Given this list of marker genes Fam107a, Fscn1, Lima1, Vil1, Gas2, Actb, Actn4, Ppp1r12c, Cttnbp2nl, Septin5 (NCBI Gene Id 29860), Coro1b, Pdlim1, Klhl2, Coro2b, Evl, Fhod1, Nebl, Myh11, Sh2b2, Pdlim2, Cnn2, Pgm5, Pxn, Bloc1s6 (NCBI Gene Id 56387), Dctn4, Tek, Ppp1r12a, Septin11, Myl12b (NCBI Gene Id 98057), Ptk2, Marcks, Myh7, Pls3, Pdlim5, Xirp2, Vcl, Amot, Lpp, Myh14, Pls1, Sipa1l3, Myh9, Fblim1, Lcp1, Ablim3, Ldb3, Gas2l2 (growth arrest-specific 2 like 2), Cryab, Rflnb, Gas2l1, Prkcz, Enah, Micall2, Mlph, Afap1l1, Myl12a, Rflna, Shroom4, Dst, Limch1, Luzp1, Pdlim4, Ilk, Zyx, Prickle4, Afap1, Actn1, Tpm4, Flnb, Tlnrd1, Tmsb15l, Myl9, Synpo, Pdlim7, Ptpn11, Tmsb15b2, Synpo2, Septin9, Trip6, Mst1r, Mprip, Dixdc1, Ablim1, Daam1, Pdlim3, Pstpip1, Palld, Cfl1, Acta2, Vangl2, Acta1 (NCBI Gene Id 11459), Fermt2, Flna, Ppp1r12b, Tpm3, Spef1 (sperm flagellar 1), Myh6, Myh10, Asb2, Ror1, Fhl3, Dlc1, Diaph3, Tpm1, Rai14, Mylk (NCBI Gene Id 68242), Cyba, Anxa2, Septin7, Nox4, Xirp1, Sorbs1, here is a description of the gene set: An assembly of actin filaments that are on the same axis but may be oriented with the same or opposite polarities and may be packed with different levels of tightness. Mouse Gene Set: GOCC_ACTIN_FILAMENT_BUNDLE species: Mus musculus